The following is a description of a gene set: Reactome Pathway: Gastrin-CREB signalling pathway via PKC and MAPK studied in species Homo sapiens Gastrin is a hormone whose main function is to stimulate secretion of hydrochloric acid by the gastric mucosa, which results in gastrin formation inhibition. This hormone also acts as a mitogenic factor for gastrointestinal epithelial cells. Gastrin has two biologically active peptide forms, G34 and G17.Gastrin gene expression is upregulated in both a number of pre-malignant conditions and in established cancer through a variety of mechanisms. Depending on the tissue where it is expressed and the level of expression, differential processing of the polypeptide product leads to the production of different biologically active peptides. In turn, acting through the classical gastrin cholecystokinin B receptor CCK-BR, its isoforms and alternative receptors, these peptides trigger signalling pathways which influence the expression of downstream genes that affect cell survival, angiogenesis and invasion part of: G alpha (q) signalling events, and this is the list of marker genes: MAPK3, MAPK7, RPS6KA3, HRAS, EGFR, MAPK1, PRKCA, HBEGF, RPS6KA1, GAST, KRAS, CREB1, RPS6KA2, NRAS, MMP3, SOS1, GRB2 (growth factor receptor bound protein 2), CCKBR